Given this list of marker genes SLC17A5, SLC5A12, SLC25A10, SLC5A8, SLC25A1, SLC25A11, here is a description of the gene set: species: Homo sapiens The SLC17 gene family encode proteins which are organic anion transporters. There are three distinct subfamilies within SLC17; vesicular glutamate transporters (VGLUT1-3 encoded by SLC17A7,6 and 8), type I Na+-coupled phosphate co-transporters (encoded by SLC17A1-4) and a proton-coupled sialic acid co-transporter (encoded by SLC17A5) (Reimer RJ and Edwards RH, 2004).<br><br>Two members of the SLC5 gene family encode carboxylate transporters, SMCT1 and SMCT2 (Ganapathy V et al, 2008). part of: SLC-mediated transport of organic anions Reactome Pathway: Organic anion transport by SLC5/17/25 transporters